Given this list of marker genes MRM2, CSF1R, NAGS, SLC2A1, CHKA (choline kinase alpha), DARS2, NUP214, SPTSSA, TAF6, C19orf12, PRKCG, FUS, IDUA, SPTBN1, REEP1, MBOAT7, SLC6A19, AP4S1, VPS35, SCYL1, BAZ1B, NSRP1, POMT1, SDHB, MTRR, TUBG1, CHMP1A, SV2A (synaptic vesicle glycoprotein 2A), HLA-DRB1, GCSH, ZNF526, VAPB (NCBI Gene Id 9217), GAS1, UBA5, FOXH1, INPP5E (inositol polyphosphate-5-phosphatase E), SLC20A2, MINPP1, SLC12A5, SCAF4, FKBP6, PCLO, CCT5, COPB2, HEXB, ADAM22, HPRT1, CYP2U1, HEXA, DMXL2, INPP5K, ERCC6, NODAL, DDB2, CEP290, MRPS34, VPS11, HCN1, NDUFA2, PTPN23, HSPD1, TPRKB, BBIP1, ZNF592, ARV1, PI4KA, SHQ1, NCAPG2, CRLF1, TREM2, NDUFV2, LSM11, FARS2, TBC1D23, CYFIP2, TSEN54, GAN, PYCR2, RNASEH2C, MT-ATP6 (mitochondrially encoded ATP synthase membrane subunit 6), GTPBP2, AP1S2, MFN2, TDP1, DNM1, C12orf57, NTNG1, NUP133 (nucleoporin 133), HNRNPH2 (heterogeneous nuclear ribonucleoprotein H2), TUBGCP2, CYB5R3, MT-TF, TAF15, LETM1, SMC1A, RNASEH2A, NCAPD3, MED25, MKKS, EIF2B2, ADAR, ADNP, ASPA, SLC32A1, TMEM106B, TPM2, RNF170, TCF20, PRUNE1, SLC19A3, RPS20, PITX3, L2HGDH, ZNF668, ABCD1, WARS2, NOP56, CDC42BPB, RBMX, PQBP1, TRAPPC4, TRAPPC12, RAB11B, LAGE3, TTPA, PCYT2, EIF2B1, SLC25A15, TRIM32, NPC1, VWA3B, NARS2, ZFR, RBPJ, BTD, GABRA5, SATB2, CARS2, CNOT1, SOX2, SOD1, KCNQ3, OPA3, DYNC1I2, BCKDHA, KAT6A (NCBI Gene Id 7994), EYA1, WARS1, ACTL6B, ARSA, SLC1A2, KCNQ2, ATP5F1D, RAB3GAP2, SETBP1, RPIA, MTFMT, KIF11, NR2F1, CLN8, MACF1, ABHD12, CACNA1G, SDHA, YWHAG, ATP5MC3, COX11, NFU1, EIF4H, PLA2G6, NDUFA13, RFT1, ARPC5, BCAS3, RAB3GAP1 (NCBI Gene Id 338380), COPB1, TGFBR2, CHP1, WDR45, AFF3, RTEL1, FGF8, DPYD, HLA-DQB1, ATRX, POLD1, SPTAN1, COASY, AARS1, ACP5, PRF1, SLC1A3, IKBKG, DALRD3, SYNGAP1, CDKL5, SCN9A, GOT2, C2orf69, TMEM67, NT5C2, FOXP1, PEX10, GRIN2B, MME, UBQLN2, KCNC2, GDAP2, RTN2, RTTN, STAG2, HMGCL, LARGE1, TARS2, RERE, SQSTM1, CCDC88C, NUS1, SYNJ1, DNMT1, PAX1, ZBTB11, RAD50, ADARB1, BRAT1, SUZ12, ALG11, NEU1, DARS1, PEX3, PLCH1, TECPR2, TSEN34, MPDU1, PEX14, MT-TL1, MDH1, ACER3, NDUFV1, GABBR2, MFF, TAF2, EXOSC5, VPS50, YIF1B, SLC17A5, LAMB1, POLR3GL, CDON, PEX7 (peroxisomal biogenesis factor 7), CHCHD2, GBA1, TUBB3, ESAM, COG3, GBA2, UNC13A (unc-13 homolog A), SLC12A2, PSAT1, ZC4H2, XPA, VAC14, FA2H, HUWE1, ANXA11, GRM1, CACNA1E, CFAP410, ABCC8, POU3F3, SLITRK2, GTF2E2, KIF5C, AMACR, PANK2 (pantothenate kinase 2), PMS2, SPOP, AQP4, FCSK, NEK1, SPG7, SCN1A (sodium voltage-gated channel alpha subunit 1), ITPR1, SNCAIP, NARS1, TBC1D20, MED12, RARS2 (arginyl-tRNA synthetase 2, mitochondrial), CHEK2, PSAP, BSCL2 (BSCL2 lipid droplet biogenesis associated, seipin), STAMBP, AGTPBP1, CNTNAP1, VPS4A, SEC31A (SEC31 homolog A, COPII coat complex component), SPART, CEP19, TP53, CNKSR2, CLCN3, ERCC2, PRRT2, NSUN2, CDK19, DDHD1, PARN, BCOR, RALGAPA1 (Ral GTPase activating protein catalytic subunit alpha 1), HTRA2, RAP1GDS1, ADD3, SLC5A6 (NCBI Gene Id 8884), SCAPER, KRAS, ODC1, CPT1C, IFIH1, POLR3A, BRF1, DHDDS, DKC1, DHCR24, RYR1, DLL1, PEX19, LYST, ZSWIM6, RNU7-1, TTC19, STIL, TUBB4A, SLC25A46, ERCC1, WDR4, EBP, IRF2BPL, PTRHD1, RAB39B, COL4A1, TTR, GJA1, ATP2B3, SHH, OSGEP (O-sialoglycoprotein endopeptidase), CARS1, MLC1, SMAD4, LIPT1, TELO2, CTC1, TGIF1, ANK3, BBS10, LIPT2, ZFYVE26, VPS53, PRDM13, TMEM63C, PAH, TXN2, IFT56, ATXN3, TMX2, IARS1, PDGFRB, LDHA, TUBA1A, PIGP, GAMT, EIF2S3 (NCBI Gene Id 8422), ISCA1, PPARGC1A, SPG11, MYO5A, MARS1, SPTBN2, ATP5F1A, ADSL, MPLKIP, MTPAP, BMPR1A, KYNU, KIF5A, CACNA2D1, SLC6A3, RETREG1, ATP6V1A, CRYAB, CEP85L, SLC35A2, COA8, AUH, ASNS, TSPOAP1, SATB1, ARX, TNR, GATAD2B, ANKLE2, CLP1, SERAC1, L1CAM, TIMM50, SORL1, CYB5A, KCND3, YRDC, MED13L, CTCF, KANK1, POLE, PHACTR1, GABRA1, HLCS (holocarboxylase synthetase), NOTCH1, AGA, PIK3CA, NAXE, ATXN10, PRPH, ERCC4, ADH1C, CTNNA2 (catenin alpha 2), PRNP (prion protein (Kanno blood group)), ELN, BBS2 (Bardet-Biedl syndrome 2), NPC2, ATXN8OS, MTHFR, SUOX, SLC6A8, GMPPA, MT-ND1, FTO, EIF2AK3, UFC1, PEX16, KCNN2, CAPN1, AFG3L2, GRIN2A, ECHS1, ZNF335, ARF1, FBXW11, SEMA6B, GLT8D1, KDM1A, NUP62 (NCBI Gene Id 51551), RFXANK, PCBD1, PEX1, EIF2AK1, GFM1, UQCRC1, FRMD4A, BBS1, TYROBP, SPAST, NALCN, APC2, PLK4, EPM2A, BBS12, NFASC, NDUFA9 (NCBI Gene Id 4721), PGAP1, H4C5 (NCBI Gene Id 8367), FMR1, STT3A, GRIA2, NEUROD2, ITM2B (NCBI Gene Id 9445), TBL1XR1, DNAJC13, DPM1, ISCA2, PFN1, RNU4-2, ERBB4, CTSD (NCBI Gene Id 196214), MTRFR, NDUFA8, ZNF292, ALG9, PTPA, TCTN2, TFG, FKRP, GPRC5B, DAB1, PARS2, POLA1, DCX, MSL3, AMFR, ATP6AP2, CAMSAP1, BEAN1, KIDINS220, MTR, CACNA1C, HECTD4, SCN8A, WDPCP, QDPR, STN1, MT-TV, EBF3, SELENOI, ALS2, HPDL, COL4A2, GFAP, REPS1, INTS8, SCLT1 (NCBI Gene Id 132320), NEFL, DLL4, PIGQ, FLRT1, RNF13, ALG3, MECP2, B4GAT1, ASXL1, KCNA4, MRAP, PDGFB, EXTL3, PIGN, KPNA3, SZT2, HID1, ABCA12, DENND5A, MT-ND2, ABCA7, GCDH, DNM1L, SYNE1, ATAD3A, AIFM1, ADCY5, AHDC1, ACBD6, PDHX, ACOX1, UCHL1, FOXG1, KIF1C, HTT, TSEN15, NEFH, VCP, TBC1D24, BBS5, DSTYK, KARS1, DCTN1 (dynactin subunit 1), ASXL3, TOE1, HNRNPC, TCEAL1, HK1, EMC1, TOR1A, MED17, ATP6V0A1, TARS1, PNPT1, SNX14, ALDH18A1, MCCC2, TP53RK, CP (ceruloplasmin), EXOSC8, OCLN, CAMLG, MED27, UGDH, PPP3CA, MAG, MICU1, TUFM, OGDH, MORC2, GSS, PLAA, ELP2, FTH1 (ferritin heavy chain 1), TWNK, PNKD, SLC25A10, SLC13A5, GCH1, FZR1, ATP1A2, PSEN1, NKX6-2, GBE1, WDR62, VPS41, TAF4, ATAD1, CKAP2L, SUCLG1, SAMHD1, POMGNT1, AMPD2, CYP27A1, UGP2, STX1A, TUBGCP4, ATN1, KCNJ6, HSD17B4, TAF8, EOGT, COX8A, PNPLA8, METTL27, ATXN2, HSD17B10, PTCD3, SLC12A6, IFT172, RNF113A, FAR1, PON3, LMBRD2, AP4E1, ERCC5, ARL6, GLB1, NTRK2, POLR1A, OTUD6B, GABRB2, IREB2 (NCBI Gene Id 3658), GABRG2, PLCB4, DLAT, SLC25A12, HS2ST1, ASXL2, KMT2B, TRIM8, EEF1A2, NOVA2, TRIT1, KIFBP, KCNT1, AP1G1, PEX12, BCKDHB, EXOC8, PEX2, EXOSC9, VRK1, TAF1, PRORP, ARG1, GTF2H5, BBS9, ADGRG1, UBE4A, WDR73, CHMP2B, AASS, ACAT1, PPFIBP1, CLPB, ATP6V1E1, COQ9, VPS37D, POLG2, NDE1, GON7, GNPTAB, SEMA4A, SDCCAG8, DEGS1, NDP, MT-TI, DYNC1H1, PIGU, PTCH1 (NCBI Gene Id 8015), FGF13, ARHGEF9, AP4M1, NDUFAF5, GPT2, OPHN1, AP4B1, ASCC3, PTS, TRMT5 (tRNA methyltransferase 5), GLRB (NCBI Gene Id 2743), SCN3A, TANGO2, NADK2, EIF4G1, HMBS, MAN2B1, GLYCTK, PSEN2, LZTFL1, DOCK6, MT-ND4, RNASET2, GNAI1, SMC3, TBCE, TBL2, NCF1, METTL5 (methyltransferase 5, N6-adenosine), PPP1R15B, MT-ND6 (mitochondrially encoded NADH:ubiquinone oxidoreductase core subunit 6), PNP, AFG2B, PACS2, WDR45B, WDR26 (NCBI Gene Id 80232), CYP7B1, LYRM7, TTC8, RRM2B, ZEB2, THOC2, AFG2A, MSH2, GRIA4, MICOS13, DNAJC30, PDE8B, PMS1, GUF1, ASAH1, CELF2, MLH1, FIG4, LOXL1, PHGDH, TUBGCP6, SLC39A14, WASHC4, ADAT3, CPSF3, RPS6KA3, IFT74, NPHP1, LRRK2, TPI1, SCN2A, VAMP1, PPT1, FDX2, SIL1, POLR1C, CLCN4, DISP1, COX15, NDUFA6 (NCBI Gene Id 4700), BCS1L, FDXR, NEXMIF, TREX1, CDC40, SLC33A1, BBS4, KCNA1, EPCAM, SCYL2, TMEM270, NECAP1, CHCHD10, ATP7A, RUSC2, KCNC3, RARS1, DHPS, NDUFAF6, JPH3, RNF220, EIF2B4, ERLIN1, MUTYH, MRE11, EXOSC3, TRMT10A, DNAJC6, MIPEP, ENTPD1, ERLIN2, SIX6, CRELD1, CNPY3, RHOBTB2, PAX3, ARL6IP1, MCEE, TOMM40, SLC25A22, SCN1B, ELOVL1, DPAGT1, FGF12, COQ2, LRPPRC, BRCA2, KCNA2, DDX3X, ATP6V0A2, COLGALT1, SLC6A9, DYRK1A, PLCB1, NDUFA4, ROGDI, GRM7 (glutamate metabotropic receptor 7), HTRA1, EIF4A2, GFM2, TSEN2, GPHN, TMEM222, MTHFS, BCL11B, DNAJC12, MOCS2, STXBP1, VPS13A, DBT, SNAPC4, DLD, SCO2, CLCF1, HNRNPA1, SPTLC1, COQ5, PLAAT3, WASHC5, NUP107 (nucleoporin 107), UNC80, WWOX, GRIA3, EML1, IBA57, NUBPL, GLE1, RFC2, PEX13, TRAK1, PARK7, PLPBP, NPHP3, TARDBP, CFAP418, TNPO2, TEFM, ATP1A3, ALDH3A2, NAA10, VPS13C, BRAF, PLP1, DHCR7, LONP1, PON1, TMEM240, COG4, PEX5 (peroxisomal biogenesis factor 5), TBCD, ABHD16A, CLDN11, SLC2A3, SLC30A9, FRRS1L, PIGA, MT-TK (mitochondrially encoded tRNA-Lys (AAA/G)), COQ4, EPRS1, SLC30A10, NOTCH3, NDUFAF4, PCCB, NAXD, GLI2, GJB1, APP, CRPPA, ACADS, UBTF, SEPSECS, TMTC3, GALC, SMPD1, BUD23, POLG, OPA1, GTF2IRD2 (NCBI Gene Id 84163), ZIC2, KDM5C, CACNA1B, SLF2, HEPACAM, TH, EZH2, OSTM1, STUB1, LNPK, CTNNB1, ARSI, SRPX2, RANBP2, MOCS1, CAMK2B, BBS7, GNB1, SLC6A5, LMNB1, PRPS1, MKS1, SOX10, ELOVL4, ASPM, LIMK1, SMPD4, MT-TP, APC, PNPLA6, SNORD118, NIPBL, PEX26, SMG9, GLRX5, NACC1, ATXN1, TBK1, SVBP, SON, FRMD5, RNU4ATAC, POLR3B, GPAA1, NDUFAF3, ATP7B, SLC18A2, ATP5F1E, GNAO1, MT-ATP8, PON2, KIF2A, RAB27A, PCDH19, EIF2AK2, PEX6 (peroxisomal biogenesis factor 6), PINK1, HDAC8, EXOC2, NIPA1, MED11, KIF1A, SUMF1, KATNB1, BOLA3 (NCBI Gene Id 388962), WDR48, PI4K2A, NOTCH2NLC, NDUFS4, GLRA1, ARNT2, PIEZO2, CRIPTO, ACD, SLC25A19, GIGYF2, PAFAH1B1, SUCLA2, FBXO7, MT-TW, SIX3, GAD1, ACTA1, TRAF7, FUCA1, GABRA2, CASP2, SHMT2, TPK1, FBLN1, GM2A, AP3B2, GSX2, SLC4A10, MT-ND3, JAM2, RAD21, MAPK8IP3, GEMIN4, POMT2, CASK, RLIM, GRIN2D, UFSP2, MT-TT, RNASEH2B, H3-3A, FOXRED1, DNAJC19, B3GALNT2, SPG21, ATP13A2, SLC38A3, GTF2I, EARS2, PSMC1, SRD5A3, FRMPD4, NDUFC2, HIKESHI, MFSD2A (NCBI Gene Id 84879), ATL1, SLC31A1, AP5Z1, MATR3, MCCC1, TINF2, PNPO, OPTN, KCNB1 (NCBI Gene Id 3745), SCN4A, DAO, ERCC8, NSD1 (nuclear receptor binding SET domain protein 1), CNTNAP2, PMPCB, GMPPB, TGFB1, HACE1, TBP, AUTS2, VPS37A, NFIX, ATPAF2, H1-4, ARHGAP31, VARS2, SIGMAR1, CLIP2, AARS2, PPIL1, XPC, LINGO1, SOX4, PSPH, CLIC2, UBAP1, NUP54, APOE, MT-ND5, PEX11B, CACNA1A (calcium voltage-gated channel subunit alpha1 A), TK2, UFM1, PRKN, MAPT, PMPCA (peptidase, mitochondrial processing subunit alpha), PCDH12, LBR, MGAT2, ARL13B, CNP, ERCC3, DTYMK, TTI1, DRG1, SLC35C1, SLC25A4, SDHAF1, MARS2, BRD4, NAGA, PNKP, PRDM8, MED23, TIMM8A, GRIN1, EDNRB, REEP2, GTF2IRD1, CLTC, ATP5MK, FTL, CAMK2A, FBXO28, IFT27, MTO1, CIT, PET100, TACO1, NHLRC1 (NHL repeat containing E3 ubiquitin protein ligase 1), RAB18, SACS, FKTN, FGFR1, SIK1, KY, ENSG00000288330, ACTB, USP8, AIMP1, SNCA, ATXN7, HSPG2, TERT, KLC2, LIAS, FLNA, BICD2, CACNA1D, DDHD2, CCNF, JAM3, COG2, PCCA, ATM, DPH5, SETX, VPS13D (vacuolar protein sorting 13 homolog D), MRPS22, B4GALNT1, MSH6, GJC2, NR4A2, GRIK2, WLS, SLC1A4, SDHD, MCOLN1, PODXL (podocalyxin like), NTNG2, SPR, SLC16A2, MECR, DYM, IMPDH2, ANG, DDC, LMX1B, FXN, here is a description of the gene set: Hypertonia Human Gene Set: HP_HYPERTONIA A condition in which there is increased muscle tone so that arms or legs, for example, are stiff and difficult to move. studied in species Homo sapiens